The following is a description of a gene set: from publication Liberzon A, Birger C, Thorvaldsdóttir H, Ghandi M, Mesirov JP, Tamayo P (PMID 26771021) Human Gene Set: HALLMARK_INTERFERON_ALPHA_RESPONSE Genes up-regulated in response to alpha interferon proteins. species: Homo sapiens, and this is the list of marker genes: CD74, IFI27, PSMA3, LAMP3, CMPK2, SAMD9L, NCOA7 (NCBI Gene Id 135112), NMI, OAS1, PSME2, STAT2, EIF2AK2, IFITM1, TDRD7, NUB1, PNPT1, TRIM14, HERC6, IRF1 (NCBI Gene Id 96501), PROCR, TRIM21, OGFR, CXCL10, IRF2, TAP1, CMTR1, MVB12A, OASL, DHX58, MX1, ISG20, CXCL11, LPAR6, UBE2L6, CCRL2, IRF9, TRIM26, TRAFD1, PSME1, C1S, CSF1, RNF31, SP110, ADAR, CD47, TXNIP, DDX60, LGALS3BP, PARP14, HELZ2, CASP8, TRIM25, TENT5A, GMPR, CASP1, IFIH1, LAP3, PSMB9, ISG15, MOV10, HLA-C, IL15 (interleukin 15), IFIT2, ELF1, WARS1, USP18, IFI44L (NCBI Gene Id 10964), IFI35, IL7, RTP4, SELL, PARP9, CNP, BATF2, BST2 (bone marrow stromal cell antigen 2), GBP2, SAMD9, UBA7, IFITM2, IL4R, RSAD2, PARP12, TMEM140, EPSTI1, IFITM3, TRIM5, IRF7, GBP4 (NCBI Gene Id 115361), PLSCR1, RIPK2, IFIT3, B2M, LY6E, PSMB8, SLC25A28, IFI30, IFI44